The following is a description of a gene set: Mouse Gene Set: SHETH_LIVER_CANCER_VS_TXNIP_LOSS_PAM4 from publication Sheth SS, Bodnar JS, Ghazalpour A, Thipphavong CK, Tsutsumi S, Tward AD, Demant P, Kodama T, Aburatani H, Lusis AJ (PMID 16607285) The molecular pathogenesis and the genetic aberrations that lead to the progression of hepatocellular carcinoma (HCC) are largely unknown. Here, we demonstrate that the thioredoxin interacting protein (Txnip) gene is a candidate tumor suppressor gene in vivo. We previously showed that the recombinant inbred congenic strain HcB-19 has a spontaneous mutation of the Txnip gene, and we now show that the strain has dramatically increased incidence of HCC, and that the HCC cosegregates with the Txnip mutation. Approximately 40% of the Txnip-deficient mice developed hepatic tumors with an increased prevalence in male mice. Visible tumors develop as early as 8 months of age. Histological analysis confirmed the morphology of HCC in the Txnip-deficient mice. Molecular markers of HCC, alpha-fetoprotein and p53, were increased in tumors of Txnip-deficient mice. The upregulation of p53 preceded tumor development; however, bromodeoxyuridine (BrdU) labeling of normal hepatic tissue of Txnip-deficient mice did not reveal increased cell proliferation. Finally, microarray analyses of tumor, non-tumor adjacent, and normal tissue of Txnip-deficient mice highlighted the genetic differences leading to the predisposition and onset of HCC. Our findings suggest that Txnip deficiency is sufficient to initiate HCC and suggest novel mechanisms in hepatocarcinogenesis. species: Mus musculus Cluster PAM4: genes down-regulated in hepatocellular carcinoma (HCC) vs normal liver tissue from mice deficient for TXNIP., and this is the list of marker genes: Amy1, Gfer, Dcxr, Ednra, Ehd3, Suox, Adamdec1, Srr (serine racemase), Akr1d1, Dcun1d1, Gas2, Aldh8a1, Acss2, Aldh1a7, Cxcl12, Mustn1, Slc47a1, Dct, Acyp1, Glo1, Aass, N4bp2l1, Cd3e, Cyp4f14, Syne2, Chpt1, Chchd7, Rmdn3, Adhfe1 (NCBI Gene Id 98255), Acad8 (acyl-Coenzyme A dehydrogenase family, member 8), Gdf2, Cfhr1, Gabre, Stard5, Ugt2b1, Plekhb1, Magix, Galc, Traf3ip2, Rgs5, Enpep, Tcf21, Galm, Dcn, Clpx, Zeb2, Calcrl, Ddc, Sod3, Baat, Agmat, Ndufb9, Dennd2b, Fmc1, Aanat, Cyp2f2, Slc22a30, Fzd9 (frizzled class receptor 9), Safb2, Cphx1, Slc25a15, Ugt3a2, Rnf19b, Repin1, Ces3b, Mpdz, Cyp2d13, Cyp2j5, Ahcy, Tcf25, Pth1r, Upp2, Htatsf1, Itga9, Nr1i3, Dennd1a, Mcm10, Bhmt2, Cyp3a25, Ppp2r5c, Igfbp5, Pja1, Inmt, Dpys, Timm9 (NCBI Gene Id 72642), Cd320, Plxnc1, Mdh1, Sugct, Fcna, Kifc2, Abhd15, Tk1, Aadat, Pbld2, Ccnf, Slc22a7 (NCBI Gene Id 54564), Slc6a12, Ghr (NCBI Gene Id 223275), Corin, Slc17a2, Slc2a5, Tgfb3, Park7, Tspyl4, Lamp2 (NCBI Gene Id 16784), Clec4f, Dph7, Cd1d1, Ngfr, Blmh, Abat, Otc, Mtch2, Car1, Dleu2, Macrod1, Atad3a, Selenow, Gpx1, Ces1e, Pnkd, Cd163, Got1, Gdf10, Cacna1e, Rab3a, Msi2, Dscaml1, Tgfbi, Ndrg2, Ddx49, G6pc1, Eva1a, Idh1, Abi3bp, Gm8615, Stk19, Mup3, Nat8f2, Leap2, Hagh, Mfn1, Cnmd, Clcn2, Zfp105, Mbl2, Mast3, Dmgdh, Gabra1, Tmem63a (NCBI Gene Id 208795), Zfp772, Acat1, Glyat, Kcnk5, Agxt, S100a1, Dpyd, Hacl1, Nat8f1, Csrp3, Abcc6, Clec4g, Paics, Sufu, Gcdh, Gsto1, Clock, Efemp1, Sult1b1, Chst15, Serpine2, Mbl1, Clcc1, Hmgcs2, Olig1, Sirt3, Ugt3a1 (NCBI Gene Id 223337), Reck, Cyp2d22, Acadsb, Tex12, Arhgap6, Ptpro, Hebp1, Nat1, Adh4, Mkrn1, Acsl1, Tex21, Asic5, Cwc15, Scnn1a, Aldh9a1, Immp2l, Tfpt, L2hgdh, Socs7, Fcgr2b, Nr2f2, Ethe1, Bhmt (betaine-homocysteine methyltransferase), Igf1, Acad9, Qdpr, Rnasel, Id4, Cyp2c54, Pcca, Kif1b, Pmpcb, Cryab, Ttyh1, Abhd3, Cyp8b1, Gabarapl1, Clec3b, Gas1, Shroom1, Ugt2a3 (NCBI Gene Id 72094), Suclg2, Acat3, Hcfc1r1, Ctnnbl1, Atp11a, Cyp46a1 (cytochrome P450, family 46, subfamily a, polypeptide 1), Coq8a, Pde9a, Pbld1, Ido2, Slc10a1, Stab2, Pdk1, Rbbp9, Cth, Tbc1d8, Tshb, Ntn1 (netrin 1), Hpgd, Dnase1l3, Cyp2g1, Prkag2, Sppl2b, Slc25a51, Gstk1, Hibadh, Rdh16, Cnga2, Atg5, Kcnq5, Kmt5b, Slc16a2, Ephx2, Gpm6a, Adtrp, Haao, Terf2ip, Il1rap, Cbs, Rnasek, Cutc, Ndn, Ptprd, Keg1, Aldh6a1, Celf2, Susd4, Mfsd4b1, Pecr, Cyp4v3, Ckmt2, Pcolce2, Asl (argininosuccinate lyase), Apol9a, Bad, Ddx60, Masp1, Car3, Epdr1, Zfp865, Ccr5, Abcb10, Sardh (NCBI Gene Id 192166), Gch1, Tprkb, Cd40lg, Spdef, D7Bwg0826e, Bag4, Hoxc9, Gdpd3, Hemk1, Gm5617, Nr1h4, H2-K1, Slc26a3, Prlr, Slc27a5, Gnmt (NCBI Gene Id 14711), Serpinb1a